Given this list of marker genes Cdkn2a (NCBI Gene Id 18560), Nod2, Mef2c, Ccr5, Pten, Ccl5, Selenos, St6gal1, Ghsr, Sirt1, here is a description of the gene set: Any process that modulates the frequency, rate or extent of macrophage apoptotic process. Mouse Gene Set: GOBP_REGULATION_OF_MACROPHAGE_APOPTOTIC_PROCESS species: Mus musculus